Given this list of marker genes Hsp90aa1, Dynll1, Nos2, Nos3, Calm3, Calm1 (NCBI Gene Id 12313), Calm2, Atp2b4, Akt1, Nos1, Hsp90ab1, here is a description of the gene set: species: Mus musculus Catalysis of the reaction: L-arginine + n NADPH + n H+ + m O2 = citrulline + nitric oxide + n NADP+. Mouse Gene Set: GOMF_NITRIC_OXIDE_SYNTHASE_ACTIVITY